The following is a description of a gene set: studied in species Mus musculus Catalysis of the hydrolysis of peptide bonds between an alpha-carboxyl group and an alpha-amino group within a small protein such as ubiquitin or a ubiquitin-like protein (e.g. APG8, ISG15, NEDD8, SUMO). Mouse Gene Set: GOMF_UBIQUITIN_LIKE_PROTEIN_SPECIFIC_ENDOPEPTIDASE_ACTIVITY, and this is the list of marker genes: Senp1, Senp7, Senp6, Senp2, Senp5